The following is a description of a gene set: Reactome Pathway: Resistance of ERBB2 KD mutants to osimertinib part of: Drug resistance in ERBB2 KD mutants This pathway describes resistance of ERBB2 KD mutants to tyrosine kinase inhibitor osimertinib. studied in species Homo sapiens, and this is the list of marker genes: ERBB2, HSP90AA1, ERBIN, CDC37